Given this list of marker genes ZNF587, DNAJC8, MTFMT, RNF24, CSF3R, DMRT1, PARP9, PRICKLE3, SBSPON, SETD7, CYP20A1, FAM72B, NUDT19, SULT1E1, HOOK3, UBXN2B, MAVS, MUCL3, PSMB2, TMTC1, DTX4, GNPNAT1, ZNF655, ESYT1, PAPOLG, IGF2BP1, CYP1A2, H6PD, VIRMA, ARID2, NCEH1, TMEM63C, TRAF3IP2, GPR83, FBXL20, NOL9, MAPK13, DCTN5, PLEKHA5, RBMS2, SYNGR1, PTPRB, RPL15 (ribosomal protein L15), PLCXD1, IKZF3, ANKS4B, PEX2, SKA1, ITLN1, GAB2, KCNIP1, EXOSC6, MS4A1 (NCBI Gene Id 931), DYDC2, CTSW, NMNAT2, CCL28, GFAP, SCGN, RHOJ, PNMA2, COL27A1, ACADSB, PDLIM2, SV2C, EFCAB2, MAZ, SHOX, HUNK, ODAPH, PYCR3, HRH2, RALB, CHTF8, VPS25, PRND, TMEM265, TIAM1-AS1, ZNF286B, RIMS3, FIBCD1, OSBPL1A, SLC6A11, NSL1, GDI1, MTCL2, APELA, ATXN1, CCDC28A-AS1, VPS13B, PI3, GNAT1, NID1, EOGT, ATP1B4, RAD51B, GCFC2, CASP10, NCR3LG1, ELK1, RAB21 (NCBI Gene Id 23011), TMEM239, ZNF814, ME2, ZFHX2, FAM72A, DDX6, SMU1, DEPDC5, STX5, MTX3, TCTN2, MRPS2, MRPL30, CPSF7, SLC2A4, BMAL2, SH3BP2, RRP15, CYP2B6, YWHAQ, PIGK, ZNF554, ACKR2, CEBPZOS, CDADC1, DAB2IP, LRRC51, CGNL1, SHISA6 (NCBI Gene Id 388336), ZNF326, SHISA7, MIP, ORAI2, SCAI, MASP1, NDST1, CD164, CDK8, ZNF674, APOBEC3F, LYZL1, PACS1 (NCBI Gene Id 55690), SCN1B, LHPP, COL11A2, GLG1, RPS27L, EEF2K, NOVA2, FOXK1, APOL6, ZDHHC15, LYZL2, ASPG, MARK4, ZNF793, UPK2, KCNJ6, SAMD4A, GFRA4, ARNT2, ARGFX, MS4A10 (NCBI Gene Id 64235), MEIOB, RRP7A, SLC35E2A, POLR2D, PYGO1, EBAG9, DUSP19, PHACTR4, ZNF490, GLS, DVL1, MDM4, ZNF432, PDE7A, GNL3L, MYO10, IRGQ, FOXP4, BCKDHB, CTDSPL, CBX5, CORO2B (NCBI Gene Id 10391), CALCR, FBXL18, ATP7B, ERBB3 (erb-b2 receptor tyrosine kinase 3), CDH1, SYBU, CASTOR2, SUSD5, ZNF544, PPP1R11, SYP, FUS, RAB37, RBM19, TMEM132E, GFOD2, here is a description of the gene set: Human Gene Set: MIR1273H_5P species: Homo sapiens from publication Chen Y, Wang X (PMID 31504780) Genes predicted to be targets of miRBase v22 microRNA hsa-miR-1273h-5p in miRDB v6.0 with MirTarget v4 prediction scores > 80 (high confidence targets).